Given this list of marker genes ALOX5, GPX4, LTA4H (NCBI Gene Id 4048), ALOX15, here is a description of the gene set: part of: Biosynthesis of EPA-derived SPMs studied in species Homo sapiens Eicosapentaenoic acid (EPA), a major ω-3 polyunsaturated fatty acid (PUFA) found in fish oil is the source of E-series resolvins, one of the specialized proresolving mediators (SPMs) that show potent anti-inflammatory and pro-resolving actions. The initial transformation of EPA can be mediated by either cytochrome P450s or aspirin-acetylated cyclooxygenase-2, resulting in 18(R)- and 18(S)-stereospecific E-resolvins. Combinations of oxidation, reduction and hydrolysis reactions determine the type of E-resolvin formed (RvE1, RvE2 or RvE3) (Serhan & Petasis 2011). Aspirin acetylation of cyclooxygenase isoforms results in changed activities. Acetylation of cyclooxygenase-1 results in its inhibition and thereby halting production of inflammatory mediators. However, acetylation of cyclooxygenase-2 transforms its enzyme activity from a cyclooxygenase to a lipoxygenase, thereby blocking prostaglandin biosynthesis and, additionally, initiating the production of SPMs. The biosynthesis of 18(R) E-resolvins is described here. Reactome Pathway: Biosynthesis of E-series 18(R)-resolvins